The following is a description of a gene set: studied in species Homo sapiens part of: Nucleotide catabolism The purine bases guanine and hypoxanthine (derived from adenine by events in the purine salvage pathways) are converted to xanthine and then to urate uric acid, which is excreted from the body. The end-point of this pathway in humans and hominoid primates is unusual. Most other mammals metabolize uric acid further to yield more soluble end products, and much speculation has centered on possible roles for high uric acid levels in normal human physiology. Reactome Pathway: Purine catabolism, and this is the list of marker genes: NUDT1, NUDT5, PNP, ADPRM, NT5C1B, NT5C2, NUDT16, NT5C, NUDT18, NT5C1A, ITPA, NUDT15, GDA, NT5E, XDH, NUDT9, DNPH1